Given this list of marker genes Ski, Prdx5 (peroxiredoxin 5), Maf1, Setd5, Nab2, here is a description of the gene set: Any process that stops, prevents, or reduces the frequency, rate or extent of transcription mediated by RNA polymerase III. species: Mus musculus Mouse Gene Set: GOBP_NEGATIVE_REGULATION_OF_TRANSCRIPTION_BY_RNA_POLYMERASE_III